Given this list of marker genes SLBP, FIP1L1, LSM11, CPSF7, LSM10, CSTF3, CSTF2T, NUDT21, SNRPG (small nuclear ribonucleoprotein polypeptide G), CPSF3, PAPOLA, CPSF4, NCBP1, CLP1, SNRPF, PCF11, CPSF2, PABPN1, CSTF1, NCBP2, CSTF2, ZNF473, SNRPE, WDR33, SNRPB, CPSF6, SNRPD3, SYMPK, CPSF1, here is a description of the gene set: studied in species Homo sapiens Human Gene Set: REACTOME_PROCESSING_OF_CAPPED_INTRONLESS_PRE_MRNA Processing of Capped Intronless Pre-mRNA